Given this list of marker genes DDX27, EXOSC2, ZNF318, S100A8, ZNF37BP, NGLY1, STARD3 (StAR related lipid transfer domain containing 3), KHSRP, RAD50, ARHGAP24, NAV3, OPRL1 (NCBI Gene Id 4987), CDC25C, BMP7, KHDRBS3, TASP1, PSMD6, DESI2, WDR12, RAD51D, MAOB, RMND1, PNMA1, CALU, KLRF1, BHLHE40, GSPT2 (NCBI Gene Id 83029), SNRPF, ACACA, TUT1, IKZF3, TFE3, CAMTA1, OXR1, USP46, ARCN1, FASTKD2, CHMP4A, FOXC2, PIN1, USP1, GET1, MEGF9 (NCBI Gene Id 1955), TMEM106C (transmembrane protein 106C), MRC1, P3H4, SLC25A36, NDUFB5, AMBRA1, HOMER2, ATF7IP2 (NCBI Gene Id 80063), UBR7, TP73, NDUFA1 (NCBI Gene Id 4694), OR7E47P, BAMBI, PIP4K2B, REPIN1, GNAI2, BAG5, BAG2, DNAJC2, ATP6V1B1, CTCF (NCBI Gene Id 10664), ISL1, FAM136A, COA7, MRPL34, ZNF131, SLC4A1AP, OR10C1, MAU2, CCDC103, MRAS, NCAPH, TSN, KRT20, POLR3K, UMPS, GBX2, MXRA7, IQSEC1, URB2, CLCA1, C1QB, ODC1, TERF2, TMEM121, RNF139, POFUT1, TMEM8B, QTRT1, THOC1, PTPN22, PYY, WWC1, PHTF1, WDR41, EPB41, SQLE, FLT3LG, HEMK1, ZNF24, TNP2, GALR3, CCNE1, CCNB1IP1, KIF3B, CDKN2AIP, POLR3D, ZBED5, TMLHE, FEN1, LYRM4, CT55, ZNF239, TBC1D1, IMP3, DDX42, CD14, ISG20L2, EMP3, CAMSAP2, TNFAIP2, NDUFAF4, RALGDS, HNF1B, CAPN10 (calpain 10), ANKMY2 (ankyrin repeat and MYND domain containing 2), SMOX, MLYCD, F2, NEO1, THNSL1, CCR5, TIMM8A, NBPF10, APPL2, KANK2, ITIH3, PMPCA, HNRNPA0, RLIG1, SEC22A, CXCR5, HMGB3P30, SLC7A11, KIAA0232, NDRG4, GMPPB, NACC2, MYOT, NKX2-5, TCAP, MYCNOS, SMYD5, MEAF6, MXRA5, CD302, IL11RA, YLPM1, TBC1D2B, ATP7B, DNAJB12, ATP6AP1, SLC5A12, UBN1, C6orf120, ALDH3B1, DYNC1LI1, TBC1D17, UBTF, CDC45, TST, GLCE, MRTFB, HPS5, ARL6IP5, ZNF638, FAM171A1, CHML, NUP50, C3orf18, UTP14A, SLC35A2, TENT5C, PRICKLE3, ENTR1, SPATA2L, PTGIR, HOXA1, ERMAP, LRRC19, NUDT3, KCNC4, EPN2, ESS2, BEND5, ZNF84, here is a description of the gene set: We investigated at which stage of maturation commitment to a stable Foxp3-expressing phenotype takes place. We assessed stability of Foxp3 expression in thymic Foxp3+ Treg subsets of different maturity, defined by CD24 expression. Next we compared gene expression profiles of Foxp3+ Treg subsets (+) of different maturity (24lo, 24int, 24hi) and could identify a set of genes that were specifically up or downregulated in Foxp3+ Tregs, but not in Foxp3- conventional T cells, in a maturation-dependent manner. from publication Toker A, Engelbert D, Garg G, Polansky JK, Floess S, Miyao T, Baron U, Düber S, Geffers R, Giehr P, Schallenberg S, Kretschmer K, Olek S, Walter J, Weiss S, Hori S, Hamann A, Huehn J (PMID 23420886) Human Gene Set: GSE42021_CD24HI_VS_CD24LOW_TREG_THYMUS_UP Genes up-regulated in thymic T reg: CD24 high versus CD24 low. studied in species Homo sapiens